The following is a description of a gene set: The movement of a granulocyte in response to an external stimulus. Mouse Gene Set: GOBP_GRANULOCYTE_CHEMOTAXIS species: Mus musculus, and this is the list of marker genes: Slit2, Sell, Camk1d, Cxcl17, C5ar1, Ccl19-ps6, Srp54a, Gbf1, Bsg, Mcu, Ccr3, Mpp1, Ccl4, Cxcl3, Ccl21a, Pde4b, Ccl3, Dpep1, Mapk1, Prkca, Ccl28, Vegfa, Lgals3, Ccl12, Cd74, Ripor2, C5ar2, C1qbp, Ccl19-ps1, Ppbp, Cmklr1, Anxa1, Rarres2, Vav1, Ppia, Slc37a4, S100a9 (S100 calcium binding protein A9 (calgranulin B)), Thbs1, Ccl24, Mapk3, Ifng, Trpv4, Trem1, Prex1, Il34, Ccl19-ps4, Edn2, Ccl19-ps3, Csf1, Csf3r, Dpp4, Fcer1g, Itgb2, Jaml, Edn3, Lyst, Cx3cl1, Cklf, Lbp, Cxcr1 (NCBI Gene Id 227288), Rac1, Trem3, Ccl22 (C-C motif chemokine ligand 22), Edn1, Tnfaip6, Jam3, Il17rc, Itgb2l (NCBI Gene Id 75978), C3ar1, Ccl21f, Ccl1, Ccl19, Il4, Il17b, Ednra, Nod2, Dapk2, Ppib, Cxcl5 (C-X-C motif chemokine ligand 5), Ccl19-ps5, S100a14, Gm5849, Ccl26, Il1b, Spp1, Mospd2, Ccl27a, Nckap1l, Itgam, Tgfb2, Itga9, Cxcl9, Cxcl13, Tnfsf18, Ccl21b, Ccl8, Cxcl1, Syk, Fcgr3, Pde4d, Ccl5, Slamf1, Thbs4, Ccl25, Cxcl15, S100a8, Il23a, Rac2, Ccl21e, Ccl2, Cxcl10, Cxadr, Cxcr2, Itga1 (NCBI Gene Id 320601), Ccl7, Ccr7, Scg2, Akirin1, Tirap, Mstn, Pf4 (NCBI Gene Id 56744), Cxcl2, Ptk2, Ccl21d, Il17ra, Xcl1, Vav3, Perp, Mdk, Dysf, Dnm1l, Ccl11, Pikfyve, Csf1r, Ptprj, Bst1